Given this list of marker genes TOP1, HMGB2, HMGB1, RPS3, PSIP1, ABL1, here is a description of the gene set: species: Homo sapiens Binding to supercoiled DNA. For example, during replication and transcription, template DNA is negatively supercoiled in the receding downstream DNA and positively supercoiled in the approaching downstream DNA. Human Gene Set: GOMF_SUPERCOILED_DNA_BINDING